Given this list of marker genes SCN2A, CNKSR2, KCNQ2, FRRS1L, KCNC2, GRIN2A, CACNA2D1 (calcium voltage-gated channel auxiliary subunit alpha2delta 1), ITPR1, TRIM8, SRPX2, TRPM3, here is a description of the gene set: studied in species Homo sapiens Human Gene Set: HP_CONTINUOUS_SPIKE_AND_WAVES_DURING_SLOW_SLEEP Diffuse, bilateral and recently also unilateral or focal localization spike-wave occurring in slow sleep or non-rapid eye movement sleep. Continuous spike and waves during slow sleep